Given this list of marker genes Ranbp9, Fgf5, Rbpms2, Cd69, Rps6ka2, Esrrg, Gpr63, Cenpp, P4ha2, Lrat, Hcn1, Tnrc6b, Cd34, Tmem30a, Idi2, Twf1, Trim8, Zkscan8, Mdga2, Ntf5, Eif5b, Kcnb1, Sorl1, Nkapd1, Insig1, Brd1, Runx1t1, Cpped1, Acsl1, Zfp148 (NCBI Gene Id 78647), Mex3a, Actmap, Nedd4l, Tardbp, Mgat1, Syt9, Nr2f6, Jph1, Dab1, Hacd4, Mif4gd, Nr2c1, Slc24a2, Fzd10, Nr0b1, Lzic, Arvcf, Dusp22, Igsf10, Wipf3, Tnks, Golph3l, Apbb2, Trpc3, Ifrd2, Slx1b, Sema6d, Gria3, Cd164, Gnb1, Gpr88, Ykt6, Hic2, Terb2, Ark2n, Marchf10, Psmb11, Gm14434, Fgf18, Bmp2k, Gk2 (NCBI Gene Id 14626), Frmd3, Zfand3, Faf1, Robo2, Tmem201, Pitx2, Rem2, Plxna4, Zfp607b, E130308A19Rik, Stk3, Spred1, Alkal2, Adra1a, Mrm1, Septin2, Phf20l1, Abca4, Zmym5, Crebl2, Prkg1, Cacnb4, Thrap3, 2210418O10Rik, Wnk1, Col1a2, Alg2, Cox19, Micos10, Tead1, Ap1s2, Zfp654, Ccng1, Gys1, Wdr76, Npas3, Ctdnep1, Usp49, Net1, Ephb1, Adam23 (NCBI Gene Id 98648), Pou2f2, Ttc17, Axin2, Col11a1, Lpgat1, Cdv3, Retnlb, Ccnyl1, Yme1l1 (NCBI Gene Id 27377), Carm1, Grb2, Gm4724, Rasgrp1, Plp1, Ubqlnl, Rnf207, Tent5c, Kdm4a, Fbln5, Mthfd2, Nrg3, Pbx3, Ralbp1, Rab18, Lurap1l, Onecut2, Mbnl1, Trip11, Synpo2l, Gramd2b (NCBI Gene Id 74540), Cnep1r1 (NCBI Gene Id 74731), Cxxc4, Rab27b, Cacna2d3, Rab11fip5, Rin2, Gm2026, Ppme1, Maml3, Slc10a1, Nhsl3, Gm14308, Tab3, Itpa, Tgfbi, Csnk1g1, Nfasc, Kctd8 (potassium channel tetramerisation domain containing 8), Zfp953, Vangl1, Ubxn7, Gm14296, Cd200r3, Oxr1, Ar (NCBI Gene Id 11835), Brcc3, Gja3, Sgip1 (NCBI Gene Id 73094), Pde3b, Card6, Tlk1, Rbms3, Gm4847 (predicted gene 4847), AW554918, Stxbp5l, Rfx6, Prkaa2, Retreg1, Rpp30, Cntnap2, Trim9, Hivep2, Zfhx3, here is a description of the gene set: Mouse Gene Set: MIR_29B_2_5P studied in species Mus musculus from publication Chen Y, Wang X (PMID 31504780) Genes predicted to be targets of miRBase v22 microRNA mmu_miR_29b_2_5p in miRDB v6.0 with MirTarget v4 prediction scores > 80 (high confidence targets).